Given this list of marker genes PRG2, FCRL3, HFE, TWIST1, CD22, IL33, IRAK3, SPINK5, TGFB3, NDFIP1, EPX, ANGPT1, ATG9A, IL10, CD96, CR1, IFNA2, FOXP3, TGFB1, NLRX1, AXL, FCGR2B, TMBIM6, ACP5, ARG1, TBX21, HLA-F, SLAMF1, LILRB1, ZPBP2, LILRB4, MIR302A, RABGEF1, JAK3, PARP3, TGFB2, CUEDC2, XCL1, BST2, APOA2, BCL6, IFNB1, APOA1, TNF, SMAD7, IL13RA2, here is a description of the gene set: studied in species Homo sapiens Any process that stops, prevents, or reduces the frequency, rate, or extent of the production of molecular mediator of immune response. Human Gene Set: GOBP_NEGATIVE_REGULATION_OF_PRODUCTION_OF_MOLECULAR_MEDIATOR_OF_IMMUNE_RESPONSE